The following is a description of a gene set: The specification of male sex of an individual organism. Human Gene Set: GOBP_MALE_SEX_DETERMINATION species: Homo sapiens, and this is the list of marker genes: NR5A1, INSR, NR0B1, SRY, PTGDR, SOX9, DMRT1, INSRR, FGF9, MAP3K4, GNRH1, AR, SIX4, DHH (desert hedgehog signaling molecule)